The following is a description of a gene set: from publication Indraccolo S, Pfeffer U, Minuzzo S, Esposito G, Roni V, Mandruzzato S, Ferrari N, Anfosso L, Dell'Eva R, Noonan DM, Chieco-Bianchi L, Albini A, Amadori A (PMID 17202376) Genes down-regulated fibroblasts: untreated versus interferon alpha. studied in species Homo sapiens Human Gene Set: GSE3920_UNTREATED_VS_IFNA_TREATED_FIBROBLAST_DN IFNs are highly pleiotropic cytokines also endowed with marked anti-angiogenic activity. In this study, the mRNA expression profiles of endothelial cells (EC) exposed in vitro to IFN-alpha, IFN-beta, or IFN-gamma were determined. We found that in HUVEC as well as in other EC types genes were upregulated (>2-fold increase) by IFNs, including genes involved in the host response to RNA viruses, inflammation, and apoptosis. Interestingly, genes showed a >5-fold higher induction by IFN-alpha in EC compared to human fibroblasts; among them, the gene encoding the angiostatic chemokine CXCL11 was selectively induced by IFN-alpha in EC along with other genes associated with angiogenesis regulation, including CXCL10, TRAIL, and guanylate binding protein 1 (GBP-1). These transcriptional changes were confirmed and extended by quantitative PCR analysis and ELISA; whereas IFN-alpha and IFN-beta exerted virtually identical effects on transcriptome modulation, a differential gene regulation by type I and type II IFN emerged, especially as far as quantitative aspects were concerned. In vivo, IFN-alpha-producing tumors over-expressed murine CXCL10-11, GBP-1 and TRAIL, with evidence of CXCL11 production by tumor-associated EC. Overall, these findings improve our understanding of the anti-angiogenic effects of IFNs by showing that these cytokines trigger an anti-angiogenic transcriptional program in EC. Moreover, we suggest that quantitative differences in the magnitude of the transcriptional activation of IFNresponsive genes could form the basis for cell-specific transcriptional signatures., and this is the list of marker genes: CSRNP2, PTPN2, UBTD1, MAP3K2, SURF2, TBC1D7, IRGM, OSGIN2, SNAP23, PLD1, TGFB1, RSRC1, CHST12 (carbohydrate sulfotransferase 12), GFM2, MARK4, GPX4 (glutathione peroxidase 4), MRPL38, VPS53, TNIP1, GOPC, ARAF, SGCE, GMDS, RNF19A, RBMX2, PLBD2, HGH1, PREP, PCGF2, EPCIP, PFKP, ZNF142, HS3ST1, RRP8, SLC35F5, DENND11, ERAP1, HEATR5B, DDX51, MSI2, SLC39A10, DDX31, PLD3, SNUPN, PLCD4, C18orf21, RAB20, FTO, UTP11, MPZL1, CHPF2, GON4L, ZDHHC13, MRPL4, HK2, ZNF81, GRK5, EIF3B, ARG1, CEP76, SLC35G1, IFRD2, ZBTB4, TXNDC9, IFITM3, TYW1, DANCR, LPP, REPIN1, IVD, GSDME, TYK2, TBC1D19, DDIT4, TRMT2A, FRRS1, GGT7, CWF19L1, CLDN12, GNL3, PEX12 (peroxisomal biogenesis factor 12), ELP5, MRS2, DHX30, IGF2BP2, SNN, ZCCHC10, PCCA, SUCLG1, ZCCHC3, JAK2, CDYL2, FCMR (NCBI Gene Id 9214, Fc mu receptor), EXOC6B, ZMYM3, ORC1, GPS1, BLTP3B, YTHDF3, ATG4B (autophagy related 4B cysteine peptidase), TEFM, MCTP1, GPI, CTDNEP1, RHOQ, FOXRED2, KRI1, IL6, LRP12, FBF1, CEP192, LRRC28, MAFG, CCDC80 (coiled-coil domain containing 80), MEX3A, GIGYF2, TNFSF9 (TNF superfamily member 9), APOBEC1, CA12, BLM, PEX3 (peroxisomal biogenesis factor 3), RNF19B, PCM1, PPP1R3D, AFG2A, IL9, PLA2G12A, ZSCAN21, SNX8, RUNDC1, CWC27, TBC1D8B, VPS41, VEGFC, ARHGEF7, THYN1, EDC4, ASRGL1, MAST3, KRIT1, ZFTA, UMPS, ZMAT1, EFTUD2, SLC52A3, EIF3D, ATXN2, RTF2, BCL7C, TMEM51, GNAQ, CCNYL1, GOLGA1, ZCCHC24, C1QBP, ABI3, XPC, RBM12, FAM43A (NCBI Gene Id 131583), WDR20, GDPD5, ATP6V1G2, UXS1, NOP14, PBX3, PES1, KMT2D, SRP54, CDC42BPA, PDE7B, DLG3, GSPT1, LIX1L, MAN1A2, LIF, GPT2, ARMC6, NAA16 (N-alpha-acetyltransferase 16, NatA auxiliary subunit), DISP1, ALG11, TBC1D9B, GSDMD, TSPYL2, UQCC6, RNF123, LRPAP1, ORC2, METTL16, FNDC10, SAC3D1, LPGAT1, ORAI3, CASP4, CHERP, ACACA, CAMKMT, OSM, AATF, ZFP62, BRI3BP